Given this list of marker genes PPP1R2, RPL23AP93, PPP4R2P3 (NCBI Gene Id 124900549), CEP19, NCBP2, RPL17P18, RNU7-18P, DPPA2P3, SDHAP2, XXYLT1, SDHAP4, FRG2FP, RN7SL447P, UBXN7, ATP13A4, PPP4R2P4, ACAP2, TM4SF19-DYNLT2B, RN7SL434P, RPL36P7, NRROS, EEF1A1P23, RNU6-910P, RNU6-821P (RNA, U6 small nuclear 821, pseudogene), FYTTD1, MUC20P1, RNU6-1101P, RN7SL738P, PPP4R2P6, RN7SL215P, UBXN7-AS1, SLC51A, LINC02026, NAA50P2, LRCH3, TNK2-AS1, LMLN, RPL31P22, SMBD1P, RNU6ATAC24P, RPSAP69, LINC02048 (long intergenic non-protein coding RNA 2048), LSG1, PIGX, MUC20, TUBB8P8, RN7SL73P, RPL31P64, MIR4797 (microRNA 4797), TNK2, KIF3AP1, ATP13A5, RPS29P3, TFRC, RN7SL36P, MUC20-OT1, ZDHHC1P1, RUBCN, LINC02028, LMLN-AS1, MIR3137, RNU4-89P, LINC01968, PPP4R2P2, TMEM44-AS2, PLAAT1, DLG1-AS1, MB21D2, NCBP2-AS1, FAM157A, LINC02037, DYNLT2B, VEZF1P1 (NCBI Gene Id 652537), XXYLT1-AS1, RNU2-11P, ATP13A4-AS1, LINC01983, OPA1, RNU1-20P, CICP6, FAM151AP1, LINC00885, BDH1, MIR6829, LRRC15, ACAP2-IT1, FBXO45, ATP13A3-DT, MIR570, RPL24P6, ANKRD18DP, MIR922, NCBP2AS2, GP5, ZDHHC19, ENSG00000276407, TM4SF19 (NCBI Gene Id 116211), RNU6-646P (NCBI Gene Id 106481386), PCYT1A, XXYLT1-AS2, APOD, CPN2, ATP13A3, SDHAP1, HES1, LINC01972, ARL8BP1, SENP5, RNU6-25P, FGF12, LINC00887, TM4SF19-AS1, LINC01063, SEPTIN14P3, PAK2, RNU6-858P, LINC02012, ATP13A5-AS1, LINC02038, DLG1, RNU6-621P, RPL35A, MELTF-AS1, TMEM44-AS1, SMCO1, MELTF, MUC4, WDR53 (WD repeat domain 53), RNU6-1279P, PIGZ, COX6A1P5, OPA1-AS1, IQCG, TMEM44, RNU6-860P, LINC02924, RNF168, RNU6-42P, FAM43A, here is a description of the gene set: Human Gene Set: chr3q29 species: Homo sapiens